Given this list of marker genes Septin9, Cep135, Fuz, Wrap73, Mark4, Mns1, Ccdc88a, Zmynd10, Dynll1, Crocc, Ppp1r35, Arhgap35, Gsk3b, Dzip1, Hap1, Tapt1, Ttbk2, Ift88 (NCBI Gene Id 21821), Saxo1, Entr1, Rab3ip, Atmin, Kctd17, Cep120, Htt, Ift20, Cenpj, Tmem67, Bbs4, Pqbp1, Ccp110, Rp1, Rab11fip3, here is a description of the gene set: Any process that activates or increases the frequency, rate or extent of the formation of a cilium. Mouse Gene Set: GOBP_POSITIVE_REGULATION_OF_CILIUM_ASSEMBLY studied in species Mus musculus